Given this list of marker genes FAM111A, MAN2B1, TBCE, TGFB1, COL1A1, here is a description of the gene set: Cortical thickening of long bone diaphyses studied in species Homo sapiens Human Gene Set: HP_CORTICAL_THICKENING_OF_LONG_BONE_DIAPHYSES Abnormal thickening of the cortex of the diaphyseal region of long bones.